The following is a description of a gene set: An endoplasmic reticulum part at which COPII-coated vesicles are produced. Human Gene Set: GOCC_ENDOPLASMIC_RETICULUM_EXIT_SITE studied in species Homo sapiens, and this is the list of marker genes: SEC31A, SEC24D, SEC23B, APOB, SEC16B, SEC24C, LRRK2, YIPF5, PDCD6IP, CTAGE1, SEC24A, TFG, VAPA, SEC31B, CTAGE8, MPPE1, HLA-A, SURF4, MIA2, MIA3, TMED5, SEC24B, PDCD6, CRYZL2P-SEC16B, SEC16A, SAR1A, CTAGE9, VAPB, CTAGE15, PREB, CTAGE6, PLPP3, SEC23A, CTAGE4, SAR1B